The following is a description of a gene set: Human Gene Set: HP_ABNORMAL_ELECTROPHYSIOLOGY_OF_SINOATRIAL_NODE_ORIGIN An abnormality of the sinoatrial (SA) node in the right atrium. THe SA node acts as the pacemaker of the heart. Abnormal electrophysiology of sinoatrial node origin species: Homo sapiens, and this is the list of marker genes: MYH7, SCNN1A, SCN10A, TRDN, KCNE2, SCN5A, RANGRF, KCNJ8 (NCBI Gene Id 3764), SNTA1, TBX5, MYPN, SDHA, SDHB, CALM1, BVES, DLST, ABCC6, KCND3, TNNI3K, MDH2, PKP2, SLC25A11, KIF1B (kinesin family member 1B), LMNA (lamin A/C), GNB5, CACNB2, SLMAP, SCN2B, EPAS1, KCNA5, SDHAF2, TNNT2, TPM3, ABCC9, DEPDC5, RET, ANK2, CACNA2D1, TRPM4, NF1, NPPA, PRKAG2, KCNE5, SDHD, HEPHL1 (NCBI Gene Id 341208), SGO1, GAA, GNB2, SCN1B, RYR1, AKAP9, KCNQ1, RYR2, KCNE1 (NCBI Gene Id 3753), GPD1L, ARSB, TMEM127, CACNA1C, MAX, DNMT3A, CALM2, MYH6, CAV3, NOS1AP, HCN4, FH, SCN4B, KCNJ5, SDHC, SCN3B, MYO1H, KCNH2, VHL, TPM2, PEX5, SEMA3A, GFM2, CASQ2, CALM3, BANF1, KCNE3